The following is a description of a gene set: Human Gene Set: MORF_PRKAG1 Neighborhood of PRKAG1 protein kinase, AMP-activated, gamma 1 non-catalytic subunit in the MORF expression compendium studied in species Homo sapiens Neighborhood of PRKAG1, and this is the list of marker genes: HSPA8, INTS10, EIF2B5, PABPN1, ATXN2L, CSTF3, CALM2, SSB, COPS6, HMGN4, ESYT1, CPSF4 (NCBI Gene Id 10898), SARS1, KDM3B, SCARB1, HADHB, CSNK1D, HNRNPA2B1, SEC61B, NFRKB, DDB1, CUL4B, PHB1, GLUD1, PWP1, RUVBL2, DIMT1, RAC1 (NCBI Gene Id 5879), VAMP3, TAF9, TCOF1, SS18, RAF1, PARG, FBXW11, SSR1, PRDX4, ZPR1, DOCK3, B4GALT3, TFAP4, KXD1, USP5, ALG3, MRPS18B, AP3S1, CETN3, SMNDC1, TOR1AIP1, TBL2, ANXA7, XPO6, HDAC2, MRPL9, RPS6KA3, AATF, POLR2A, NCBP2, YIF1A, BMS1, TCEA1, GNL2, VGLL4, DDX18, CLSTN1, CSNK1G2, SGTA, SNRNP200, PDXDC1, SART3, NIPSNAP2, SLC25A11, SUMO4, RFC1, HLTF, NFYB, YWHAQ, ILVBL, DEXI, POLR2C, OARD1, MFN2, ENTREP3, SDHA, PPP2R1A, ABR, SEC63, TPR, CANX (calnexin), NUP188, EIF3I, NAP1L4, ILK, PLIN3, GLG1, MGAT1, GPAA1, CLTC, RABAC1, PARP2, MLEC, DAP3, OTUB1, XPO7, MARS1, SFSWAP, RTCA, PRKCSH, ADAM15, RTCB, MYCBP, COX8A, PMM2, RAB1A, SUMO2, ATXN2, MRPL28, PCGF1, ATP6V1F, TOMM34, BPHL, SH2B1, EPRS1, METAP1, ZNF271P, CAPZA1, NDST1, PKMYT1 (NCBI Gene Id 9088), CSNK2A1, CHD3, RPA2, EHBP1, BAHD1, ZNHIT3, CNP, PARN, SEPTIN7, SEC31A, NELFB, EML3, ARCN1, CAD (carbamoyl-phosphate synthetase 2, aspartate transcarbamylase, and dihydroorotase), LRPPRC, BRD8, CIB1, ZZZ3, CDC25C, PSMD2, BRD3, NONO, RPN2, DNAJC7, ALDH4A1, DNAJC8, SMAD2, AHCYL1, CS, TIAL1, MZF1 (myeloid zinc finger 1), UBE2A, KHDRBS1 (NCBI Gene Id 10657), ILF2, PSMD3, STK19, GFUS, DRAP1, LSM12, PSMB6 (proteasome 20S subunit beta 6), GOLGA3, ACTL6A, NSL1, PRPF8, HNRNPL, AGPAT1, SLC4A2, KPNA6, AP3B1, MTX1, ANKRD17, ATP11B, TMED1, NCOR2, BECN1, PRKAG1, UBE3C, CCT4, TXLNA (NCBI Gene Id 200081), SDR39U1, CNOT3, MPST, HUWE1, PPP1R11, MEA1, FANCG, NIPSNAP1, ZFTRAF1, DRG1, SEC62, KMT2D, TERF2IP, MTA1, P4HA1, EBP, AFG3L2 (AFG3 like matrix AAA peptidase subunit 2), SERP1, TMEM94, ST13, COQ9, LANCL1, NUP62, RPRD2, HNRNPH2 (NCBI Gene Id 3188), MCFD2, CTDNEP1, NUDT3, SRRT, PIGC, VARS1, CAPZB, TP53BP1, MMS19, RTN4, SEC23IP, ARIH2